Given this list of marker genes E2F1, TRIB3, DDIT3, SGPL1, ATF5, BID, EGLN3, NR4A1, here is a description of the gene set: Transforming growth factor-beta (TGFbeta)-activated signalling pathways can lead to apoptosis, growth arrest or promotion of malignant behaviour, dependent on cellular context. The molecular mechanisms involved in TGFbeta-induced apoptosis remain controversial; although changes in gene expression are thought to be pivotal to the process, several different candidate apoptotic initiators and mediators have been proposed. Smad4, a critical component of the TGFbeta-induced transcriptional machinery, is shown here to be essential for induction of apoptosis. Gene expression analysis identified the proapoptotic Bcl-2 family members, Bmf and Bim, as induced by TGFbeta, dependent on both Smad4 and p38 function and the generation of reactive oxygen species. TGFbeta-induced Bmf and Bim localize to cellular membranes implicated in apoptosis. Inhibition of the TGFbeta-induced expression of both these proteins together provides significant protection of cells from apoptosis. The TGFbeta-triggered cell death programme thus involves induction of multiple BH3-only proteins during the induction of apoptosis. Apoptotic genes dependent on MAPK1 and down-regulated in AML12 cells (hepatocytes) after stimulation with TGFB1. species: Mus musculus from publication Ramjaun AR, Tomlinson S, Eddaoudi A, Downward J (PMID 16909112) Human Gene Set: RAMJAUN_APOPTOSIS_BY_TGFB1_VIA_MAPK1_DN